The following is a description of a gene set: Catalysis of the reaction: H2O + N6-(2E)-butenoyl-L-lysyl- = (2E)-2-butenoate + L-lysyl-. studied in species Homo sapiens Human Gene Set: GOMF_HISTONE_DECROTONYLASE_ACTIVITY, and this is the list of marker genes: HDAC2, HDAC3, SIRT1, HDAC8, HDAC1